The following is a description of a gene set: This pathway depicts the binding of an experimentally-verified range of ligands to FGFR3c. While binding affinities may vary considerably within this set, the ligands listed have been established to bring about receptor activation at their reported physiological concentrations. species: Homo sapiens Reactome Pathway: FGFR3c ligand binding and activation part of: FGFR3 ligand binding and activation, and this is the list of marker genes: FGF4, FGF20, FGF2, FGFR3 (fibroblast growth factor receptor 3), FGF5, FGF23, FGF18, FGF9, FGF17, FGF1, FGF8, FGF16, GALNT3